The following is a description of a gene set: species: Homo sapiens Genes predicted to be targets of miRBase v22 microRNA hsa-miR-4277 in miRDB v6.0 with MirTarget v4 prediction scores > 80 (high confidence targets). from publication Chen Y, Wang X (PMID 31504780) Human Gene Set: MIR4277, and this is the list of marker genes: MBLAC2, SGMS2, GRK5, F5, ELK3, PAQR6, MAPK9, RAB2A, VPS37B (NCBI Gene Id 79720), BRMS1L, RUNX1T1, RNF6, RAB23, LYRM4, TMPRSS11F, SOX11, RORA, SENP6 (SUMO specific peptidase 6), MTHFD2, DUSP11, ERC1, PPP2CA, PRDM16, AKAP8, DDIT4, RACGAP1, FOXJ3, RBM41, ALAD, SPPL3, DIO2, NRP1, PDYN, MBTD1, PTCH1, DDO, RUBCN, CREM, CDK19, FOXO1, CPPED1, RYR2, CH25H, FNTA, DDX21, ZNF770, SNCA, SMARCA2, HARS2 (histidyl-tRNA synthetase 2, mitochondrial), CNST, ELK4, PPP4R2, GPR37, NUP42, RAP1A, RANBP6 (NCBI Gene Id 26953), ZBTB20 (zinc finger and BTB domain containing 20), MYEF2, TACC1, CHP1, GART (NCBI Gene Id 2618), FOXA1, ZNF330, CCDC6, KIAA1958, CD200R1, CYP3A4, RASSF8, YTHDC1 (NCBI Gene Id 91746), MYNN, SLC35A5, FGF5, INPP5A, CASZ1, BAALC, ARPC1A, NCBP1, EIF4E3, PYGO1, DHX15, USP13 (NCBI Gene Id 8975), ZNF22, FNDC3B, GTF2E1, FREM2, ENOSF1, TLK1, IKZF1, HIPK4, SLK, HNRNPU, SUMO1, PURA (purine rich element binding protein A), GRAMD1C (GRAM domain containing 1C), SMARCD1, PHF20L1, WDR26, STXBP4, HIF1AN, PURB, NXF1 (nuclear RNA export factor 1), G0S2, ZC4H2, MAP3K15 (NCBI Gene Id 389840), ITPR2, NEXMIF, SPOPL, SSPN, DENND5B, CNOT2, SLIT2, CNPPD1, GALNT1, RAB3C, JAZF1, RANBP1, CDH11, STXBP5L, CCN2, EP300, REG1A, SPTY2D1, SKI, YIPF6